The following is a description of a gene set: studied in species Homo sapiens Genes predicted to be targets of miRBase v22 microRNA hsa-miR-146a-3p in miRDB v6.0 with MirTarget v4 prediction scores > 80 (high confidence targets). Human Gene Set: MIR146A_3P from publication Chen Y, Wang X (PMID 31504780), and this is the list of marker genes: IL17RD, PDS5A, ZFYVE26, LYN, SLC44A1, ONECUT2, ACTN4, PRR9, PCDH17 (NCBI Gene Id 27253), CPLX2, PTPN12, DNAI4, ILF3 (interleukin enhancer binding factor 3), SPRY3, TAF1B, ETNK1, PPP1R3B, CLCN6, GFRA1, ASXL3, MEA1, AGBL3, ZBED10P, HYCC2, HSPD1, EIF4E3, KDELR3, MBLAC2, EVA1A, MED14, ZFX, FANCL, USH2A, ARHGEF12, CAND1, GCC2, MAP3K2, DUSP13B, MARCHF6, HOXC4, RASSF8, SELENOT, ZKSCAN1, STXBP6, IRGQ, KIDINS220, ZEB1, ARID4A, HIC2, VAV3, SNAP23, IGSF3, ADNP2, ERC1, TRIM36, CLEC6A, VAPB, NFYA, ABL2, SLC16A6, ERLIN1, SLC26A7, ZNF322, ETS2, KDM5A, ZNF12, MYL12A, LRP8, SNAI2, FOXJ2, TAOK1, TNKS, SMCO4, TMEM268, NRCAM, DTWD1, ATXN1, RTN4, SLC30A4, ZFTA, CDCA7, CDKN2AIP, MEOX1, CCM2, SORT1, PMEPA1, ZEB2, RAG1, RUNX2, PAN3 (NCBI Gene Id 376186), SGCG, SV2C, SNX27, NNT, DIRC1 (disrupted in renal carcinoma 1), ZNF330, NEK7, ZNF709, TRABD, CD207, ATG13, NFAT5, SHISA6, NPAS3, ITGB8, TMEM87B, KCNC2, ZNF250, AVPR1A, PTPN14, C5orf63, IDI2 (NCBI Gene Id 91734), SPRTN, NHLH2, C6orf62, SLC24A4, LCOR (ligand dependent nuclear receptor corepressor), IGF2R, DMRT3, FOXC1, MAP6, UNC13A, AHCYL1, TMEM154, PCSK5, HIF1A, TXNIP, NSUN7, AAMDC (adipogenesis associated Mth938 domain containing), AFAP1, TMEM232, B9D1, ADAMTS17, SIX4, WARS2, MTX3, STRADA, KALRN, SERBP1, TBC1D5, LHFPL5, TRDMT1, SLC38A1, CACUL1, MASP1, ZNF37A, ZC2HC1C, CD164, ATP6V1C2, XPO4, WDR7, CORO1C, CENPN, NUBP1, ZNF441, ZFP1, CAMK1D, SLC16A1, NEK2, SPRED1, LIN28B, FOXN2 (forkhead box N2), C17orf75, ITGB7, TFE3, YTHDF2, ACKR3, HRH4, SV2B, MICU3, PLCXD3, DIXDC1, KLF8, NEUROD4, CNR2, BNIP2, CASP7, DUSP13A, PCNX1, WWTR1, TRAF3IP1, KPNA1, LMNB2, MEF2C, RC3H1, BMP2, HABP2, SPRYD7 (NCBI Gene Id 65073), RFPL4B, CHD2 (chromodomain helicase DNA binding protein 2), LMO4, TBC1D4, FZD4, PTPDC1, SNAP91, ZNF71, TMEM59, SERTAD2, NUFIP2, ARL8B (ADP ribosylation factor like GTPase 8B), OSBPL3, RIOK3, ZNF395, UBFD1, ZNF236, TRIM34, LGI2, GALNT15, TRIM6-TRIM34, ZHX3, TRIM39, BNC2, ZNF140 (NCBI Gene Id 7699), SP100, HMGCR